Given this list of marker genes SLC36A4, SLC7A8, SLC36A2, SLC6A14, SLC38A7, SLC38A1, SLC36A3, SLC38A3, SLC1A4, SFXN1, SLC38A2, SLC38A4, SLC38A5, SLC3A2, SLC36A1, SLC6A6, here is a description of the gene set: Human Gene Set: GOMF_ALANINE_TRANSMEMBRANE_TRANSPORTER_ACTIVITY Enables the transfer of alanine from one side of a membrane to the other. Alanine is 2-aminopropanoic acid. studied in species Homo sapiens